The following is a description of a gene set: Mouse Gene Set: GOBP_REGULATION_OF_COLLATERAL_SPROUTING Any process that modulates the frequency, rate or extent of collateral sprouting. species: Mus musculus, and this is the list of marker genes: Rnd2, Wnt3, Lpar3, Ngf, Bcl11a, Fgf13, Wnt3a, Omg, Spart, Efna5, Crabp2, Dcx (doublecortin), Ist1, Sema4d, Lrp1, Ptprs, Ulk1, Epha7, Ulk2, Ifrd1, Fstl4, Rgma, Bdnf